The following is a description of a gene set: species: Homo sapiens Human Gene Set: GSE35543_IN_VIVO_NTREG_VS_CONVERTED_EX_ITREG_UP Induced Treg (iTreg) cells are essential for tolerance and can be used therapeutically, yet their stability in vivo and mechanisms of suppression are unresolved. Here, we used a treatment model of colitis to examine the role of autologous IL-10 in iTreg cell function. Mice treated with IL-10+/+ iTreg cells in combination with IL-10–/– natural Treg (nTreg) cells survived and gained weight, even though iTreg cells were numerically disadvantaged and comprised just ~20% of all Treg cells in treated mice. Notably, ~85% of the transferred iTreg cells lost Foxp3 expression (ex-iTreg) but retained a portion of the iTreg transcriptome which failed to limit their pathogenic potential. The TCR repertoires of iTreg and ex-iTreg cells exhibited almost no overlap, which indicates that the two populations are clonally unrelated and maintained by different selective pressures. These data demonstrate a potent and critical role for iTreg cell produced IL-10 that can supplant the IL-10 produced by nTreg cells and compensate for the inherent instability of the iTreg population. from publication Schmitt EG, Haribhai D, Williams JB, Aggarwal P, Jia S, Charbonnier LM, Yan K, Lorier R, Turner A, Ziegelbauer J, Georgiev P, Simpson P, Salzman NH, Hessner MJ, Broeckel U, Chatila TA, Williams CB (PMID 23125413) Genes up-regulated in comparison between in vivo derived natural T reg (nTreg) and converted ex-iTreg (induced T reg that lost FOXP3 expression)., and this is the list of marker genes: DNLZ, BCAR3, CDC34, SACS, ADIPOQ, TXNL4A, PPP1R14D, CCDC177, DMBT1, B3GAT3, GLA (galactosidase alpha), MYG1 (NCBI Gene Id 60314), PDRG1, ENSG00000248540, BEX2, DNMT3A, PPIAL4A, ACTG1P17, SLC25A4, WDR36, RPL26L1, DHX30, TOP3B, TIMM13, PTGER3, TMEM208, SARM1, MATN2, MRPL15, DCX, GOT1L1, LONP1, MSR1, PPP1R14B, NME6, SLC7A5, IL5RA, HEATR1, KRT78, QRFPR (pyroglutamylated RFamide peptide receptor), PFDN2, SMAD5-AS1, EOLA1, UQCRFS1, METTL16 (methyltransferase 16, RNA N6-adenosine), SPATA31F2P, PREPL (NCBI Gene Id 9581), PNPLA4, NOP16, BCCIP, ATXN1, LAMC2, GTF3C2, ARFGAP1, PAK1IP1, U2AF1, NOL6, BOLA3, LHX6 (LIM homeobox 6), KCNK4, NDUFAF3, SDK2, ANKRD35, SLIRP, HCCS (NCBI Gene Id 4307), DIRAS1, TXNDC17, RSPH9, FEM1A, ZNF491, DCST2, COPRS, MPDZ, FARSB, NDUFAB1, F7, SF3B5, TTC27, COA5, CTNNA3, CEACAM7, YDJC, ROPN1B, LOH12CR2, TSFM, CHRNG, ALDH1L1, RANBP1, MAD2L1BP, TDH (NCBI Gene Id 83649), LAMB2, PHOX2B, KCTD12, LILRA2, GRIK3, METRNL, PRMT1, THRSP (thyroid hormone responsive), TMEM70, UQCC6, RAB27B, C1orf122, FITM2, AIMP1, TBRG4, THUMPD2 (THUMP domain containing 2), LOX, SND1-IT1, CACNA2D3, CSTF2, HOXA10, ITGB1BP1, PGAM5, SNORA72, EIF2B3, OR2F2, DBI, ALKBH2, TAS2R40, CCDC148, NDUFAF8, LINC02092, SRRD, CAD, RGS16, CRIM1-DT, MRPL12, FKBP2, MIR21, KRT14, JOSD2, PDCD5, SLC35B1, H1-4, RARRES1, OPA1, DDX52, MRPS24, MIR99AHG, MRPL46, ZNF16, NSFL1C, NOXRED1, BPIFA2, SRP19, KCNK3, KRTAP8-1, ELAC2, LRRC14, LSM4, SETMAR, IL17F, CYP11B1, ULBP2, ASIC2, SYT4, ATF5, RENBP, EVA1A, WDR74, KLLN, NEIL2, CCNQ, ACTR5 (NCBI Gene Id 93972), NLE1, SEC61B, BYSL, NLGN1 (neuroligin 1), UGDH, TOMM5, SOSTDC1, AHSG, HGH1, DRAIC, CUZD1, MARVELD3, MED14, CCDC107, SPEN, MRPL17, PHACTR1, GALP, SEMA3C, MRPL47, PRPF19, SNHG15, ANAPC10, PGP, ZNF326, NLRC5, CEACAM4, CMC2